Given this list of marker genes PRKAA1, TUBB3, TUBA1B, PRKAB2, TUBA3E (NCBI Gene Id 150521), TUBA1C (NCBI Gene Id 84790), PRKAG1, TUBB8, PRKAG3, CALM1, TUBB2A, MAPT, CAMKK2, TUBA1A, PRKAA2, TUBA3D, PRKAB1, TUBB4A, TUBAL3 (tubulin alpha like 3), TUBA4B, TUBA3C, TUBA8, TUBB2B, TUBB8B, TUBB1, TUBA4A (NCBI Gene Id 93373), TUBB4B, PRKAG2, TUBB6, here is a description of the gene set: Human Gene Set: REACTOME_ACTIVATION_OF_AMPK_DOWNSTREAM_OF_NMDARS studied in species Homo sapiens Activation of AMPK downstream of NMDARs